Given this list of marker genes PLAG1, RORB, GFPT2, BORCS8, BAGE2, RALGAPA2, ARL15, PTP4A3, TLCD4, CCN4, ERGIC1, NALF1, HMGCLL1, CAP1, PAIP2B, MMD2, NR2F2, CNR1, MYCBP2, SPEG, SNAP25, CLCN3, PTPN1, FMR1, MTPN, RSKR, UBL3, PRPF38B, HOXA5, VPS29, ETNK2, ARL8A, WASF3, PAX6, DND1, FAM118B, DNAJA2, SLC39A7, ZFHX4, ELAVL2, PDCD6IP, PNLDC1, VPS35L, AQP6, TOMM6, DDX3X, TXNDC17, FCRL2, TMED4, CDK8, RAB10 (RAB10, member RAS oncogene family), SLIT2, USP35, AAK1, UNC45B, MAP3K9, PACS2, ARF3, LSM11, MAU2, BOD1, WDFY3, SPCS2, SLC18B1, ZNF709, LY75, SSH1, H6PD, PRDM6, PCDH17, ZIC3, LCMT2, URGCP-MRPS24, UBXN7, TGIF2, FBXW7, NR2F1, DKC1, LRRC59, ARHGAP12, FYN, DOP1A, CASP10, HEG1, YTHDF3, STX1B, UBE2N, MTMR4, BCL11B, XK, TMEM121B, here is a description of the gene set: Human Gene Set: MIR4436A from publication Chen Y, Wang X (PMID 31504780) Genes predicted to be targets of miRBase v22 microRNA hsa-miR-4436a in miRDB v6.0 with MirTarget v4 prediction scores > 80 (high confidence targets). species: Homo sapiens